The following is a description of a gene set: Decreased/absent ankle reflexes studied in species Homo sapiens Human Gene Set: HP_DECREASED_ABSENT_ANKLE_REFLEXES, and this is the list of marker genes: KLHL9, TWNK, SCN11A (NCBI Gene Id 337933), PMP22, GJB1, MORC2, HARS1, SLC25A4, HINT1, ARL6IP1 (NCBI Gene Id 56166), ATP6AP2, SCN10A, RFC1, ATXN3, HSPB3, SMN2, VCP, OPA1, PEX10, GNB4, PDK3, SIGMAR1, VPS13A, CRYAB, PGM3, RTN2, KLC2, REEP1, NEFL, SQSTM1, AARS1, TOR1A, COG8, MRE11, SCN9A, PLEKHG4, GNE, DYSF, MFN2, OPA3, ALDH18A1, SCO2, SMN1 (NCBI Gene Id 91918), POLG2, CCDC47, RAB7A, MPV17, CADM3, PMP2 (peripheral myelin protein 2), RAI1, RRM2B, POLG, WARS1, XK, GBE1, SACS (NCBI Gene Id 26278)